Given this list of marker genes Smcr8, Scn2b, Fbxl7, Tet1, Rarb, Txlna, Atg10, Lair1, Mbnl1, Myog, Pcdh10, Stat1, Actr3, Nom1, Semg1, Nsf, Sumo2, Cttnbp2, Ctbp2 (NCBI Gene Id 52060), Akr1c13, Hps5, Tmprss11e, Xirp1, Strn4, Gdnf, Tpm4, Synpo2l, Asrgl1 (asparaginase like 1, NCBI Gene Id 66514), Mpped1, Chrd, Myct1, Cdk8, Senp1, Rheb, Fbln7, Jak1 (NCBI Gene Id 319959), Tirap, Tmem72, Jun, Ikzf2, Ppp1r12c, Dph5, Mtmr3, Col25a1, Rab9, Phip, Dimt1, Rbpj, Sf3a1, Acnat1, Tmem87a, Bcorl1, Jazf1, Sgpp1, Zfp672, Adamts8, Creb3l1, Lrrc30, Kctd14, Ppfia2, Rgs7, Esr2, Tm4sf1, Foxp4, here is a description of the gene set: Mouse Gene Set: MIR_7115_3P from publication Chen Y, Wang X (PMID 31504780) species: Mus musculus Genes predicted to be targets of miRBase v22 microRNA mmu_miR_7115_3p in miRDB v6.0 with MirTarget v4 prediction scores > 80 (high confidence targets).